The following is a description of a gene set: Human Gene Set: HP_ABNORMAL_AORTIC_MORPHOLOGY Abnormal aortic morphology studied in species Homo sapiens An abnormality of the aorta., and this is the list of marker genes: EGFR, GATA6, LUZP1, ANGPTL6, COMT, ZMPSTE24, RAD51, SLC25A24, PPP1CB, COL1A1, MAT2A, BUB3, CFAP53, TAF4, UBE2T, TPM3, HRAS, PUF60, TGFB3, DNAJC30, CHST3, PALB2, IDS, IFIH1 (NCBI Gene Id 64135), PCSK9, RPS20, LZTR1, NAE1, CRELD1, LRPPRC (NCBI Gene Id 10303), RPS7, TBX20, FANCM, RPL35A, CDON, ZNF148, ROBO4, MYPN, PIGA, SOS2 (SOS Ras/Rho guanine nucleotide exchange factor 2), RPL8 (ribosomal protein L8), MAP2K1, ERMARD, RREB1, NDUFB11, NKX2-5, EIF4H, WDPCP, GLI3, BCOR, UBE4B, ZEB2, MFAP5, ADA2, TGIF1, FGFR1, PKD1L1, APC2, RBM8A, RIT1, NCF1, ERCC8, METTL27, ALDH18A1, SIX3, SLX4, TBX1, TMEM270, CASZ1, RIN2, GATA1, WDR26, GLI2, PTPN11, SMAD4, JAG1, GTF2IRD2, DNAJB11 (NCBI Gene Id 51726), RASA2, KMT2D, BRIP1, DDX3X, FBLN5, TNNT2, WT1, ENG, MAD2L2, CARS1, CRKL, RPS19, THSD1, SKI, HCCS (NCBI Gene Id 4307), TPM2, SEC24C, AMER1, ARVCF, ACVR2B, SPTBN1, MAPK1, GP1BB, ZIC3, TMTC3, COL5A1, TSC2, ALDH1A2, RERE, FKBP6, ACTA2, SLC12A5, NODAL, NSMCE2, NEDD4L, VPS37D, NKX2-6, C12orf57, SRCAP, FANCF, MRAS, XRCC2, PPP2R1A, FANCB, LDLRAP1, TRRAP, STIL, TRAF7, SCN2A, NOTCH1, TELO2, GDF1, SLC2A10, SLC34A2, RPL18 (ribosomal protein L18), APOE, FBN2, FANCE, STAG2, FGF8, MYRF, NOTCH3 (NCBI Gene Id 791), DHCR7, TGFBR1, RNU7-1, TALDO1, AFF4, UNC45B, FANCI, ATP6V1A, CREBBP, BUB1, RPS26, BUD23, POLR1A, PIK3R2, FLI1 (NCBI Gene Id 2313), ZMYM3, PKD2, FOXH1, RPL35, KRAS, PRDM16, KANSL1, IFT56, SUPT16H, SPECC1L, RPS15A, RPL9, STRA6, LOX, MMP14, LMNA, RPS27, HEY2, HNRNPK, PIGN, KCNH1, COL5A2, MYCN, GNB2, RAP1B, PLXND1, ARF1, LIMK1, DISP1, DLL1, APOB, FANCD2, RAD51C, TUBG1, PAH, TSC1, ATN1, P4HA2, RPL31, TBCK, EHMT1, MEIS2, RAI1, DIS3L2, ALG3, FANCC, CLIP2, TGFB2, ESS2, SPRED2, NIPA1, SOS1, KCNAB2 (NCBI Gene Id 8514), RPS10, NSD1, MLX, RRAS2, SEMA3E, PTEN, PTH1R, PGM3, IL12B, FMR1, PLD1, COL1A2, TAB2, ADAMTS19, STX1A, CTCF, AEBP1, BUB1B, NIPA2, MED12, FANCL, CDK8, SLC25A22, NRAS, SMAD3, ARFGEF2, PRKCZ, MAP3K7, ADAR, RNASEH2A, GAS1, ATP6V1E1, DYNC2LI1 (dynein cytoplasmic 2 light intermediate chain 1), TBL2, FGFR2, CLXN, NOD2, MID1, EMILIN1, HIRA, CHRNG, LDLR, MKS1, FANCA, ALG5, TMEM260, RPL11, COX7B, HLA-B, MYH3, NR2F2, UBE3B (NCBI Gene Id 89910), CRIPTO, SRY, FBXO11, SAMHD1, PLOD1, DGCR8, RPL27, JMJD1C, PLCB1, COL3A1, CIROP, IPO8, RFC2 (NCBI Gene Id 5982), LARS2, DNMT3A, FOXE3, IFNG, GTF2IRD1, RTL1, NXN, MCTP2, RNU4ATAC, WAC, KDM5A, TREX1 (NCBI Gene Id 82474), PDPN, ALG9, SCN1A, RPS17, BICC1, GJA8, HEATR3, MMP2, DLK1, ZFX, GABRD, BRCA2, NF1, ERCC6, FLNA, ATP2B1 (NCBI Gene Id 490), SCAF4, ENPP1, TBX5, FOXF1, DNAH1, BAZ1B, ABL1, LSM11 (LSM11, U7 small nuclear RNA associated), SHH, PTCH1, FBN1, BRAF, ZIC2, MEG3, PTPN22, RFWD3, ABCC6, RNU4-2, FANCG, MAP1B, CBL, DNAH9, TGFBR2 (transforming growth factor beta receptor 2), CPLANE1, DGCR6, TGFBR3, RPL15, TGDS, EFEMP2, KCNT1, RPS24, THSD4, RAF1, GJA5, MMP21, KCNQ2, NPR3, MMP23B (matrix metallopeptidase 23B), DPH5, GATA5, HLA-DRB1, SUCLG1, NEK9, FLT4, CHD4, HGD, FLNB (NCBI Gene Id 8413), NKAP, BCR, ELN, MYLK, SMAD2, GBA1, BGN, ABCG5, ADK, IFT140, PKD1, DOHH, TBC1D24, B3GAT3, RPS29, CDH2, ABCD4, GANAB, RNASEH2B, LYN, CYP7A1, SMG9, PGM1, HDAC4, UFD1, YY1, RRAS, KDM6A, NAA60, HSPG2, BRF1, B3GALT6, TRIP13, RNASEH2C, PRKG1 (protein kinase cGMP-dependent 1), THBS2, SMAD6, TSR2, SPEN, CEP57, DGCR2, BRCA1, ROR2, ERCC4, EP300, RPS28, RPL26, MYH11, GJA1, SF3B2, GTF2I, FKBP14, CHD7, ABCG8, OSGEP, GATA4, RPL5, MYH7, SMARCA2